The following is a description of a gene set: species: Homo sapiens Human Gene Set: GOBP_TIGHT_JUNCTION_ORGANIZATION A process that is carried out at the cellular level which results in the assembly, arrangement of constituent parts, or disassembly of a tight junction. A tight junction seals cells together in an epithelium in a way that prevents even small molecules from leaking from one side of the sheet to the other., and this is the list of marker genes: MYLK3, CLDN8, CLDN22, SNAI1, IKBKB, IL1B, TBCD (NCBI Gene Id 6904), CLDN4 (NCBI Gene Id 1364), MICALL2, SLC39A9, CLDN16, PARD3, NPHP1, CDH5, ACTG1, PRKCH, ECT2, EPHB2, PLEC, WNT11, MPDZ, RAMP2, ARL2, AFDN, CLDN1, TGFBR1, TGFB3 (transforming growth factor beta 3), MIR105-1, MIR142, TJP1, GRHL2, SRF, OCEL1, CLDN19, SVEP1, PDCD6IP, CLDN5, NPHP4, POF1B, CLDN11, STRN, RAC1, ILDR1, EXT1, PRKACA, CLDN34, CLDN25, TNF, CLDN10, DSG3, ROCK2, ABCC8, IL17A, OCLN, EPHA2, PATJ, PAK2, CLDN18, MYO1C, CLDN23, CLDN3, RAB13, LSR, CLDN15, CLDN9, DLG1, FRMPD2, CLDN2, MPP7, CLDN17, GDF2 (NCBI Gene Id 51423), CLDN7, MARVELD2, CLDN24, CLDN12, APC, F11R, ESAM, SNAI2, GPBAR1, FZD5, MARVELD3 (MARVEL domain containing 3), CLDN14, CLDN6, ACVRL1, ROCK1, CLDN20, PECAM1, RPS6